Given this list of marker genes PHLDB2, PHLDB1, PKD2, CLASP1, CLASP2, here is a description of the gene set: The region that lies just beneath the plasma membrane on the basal edge of a cell. studied in species Homo sapiens Human Gene Set: GOCC_BASAL_CORTEX